Given this list of marker genes Gp1ba, F13b, F13a1, Gp5, Fgg, F8, Fgb, Flna, F2, Gp9, Itgb3, Fga, Apoh, Gp1bb (NCBI Gene Id 14724), Fbln1, Pdia4, here is a description of the gene set: A protein activation cascade that contributes to blood coagulation and consists of the cascade of enzymatic reactions initiated by physical damage to the wall of a blood vessel, leading to the formation of a formation of a fibrin clot at the site of the injury. The process also includes numerous positive and negative regulatory events. Mouse Gene Set: GOBP_BLOOD_COAGULATION_FIBRIN_CLOT_FORMATION studied in species Mus musculus